The following is a description of a gene set: studied in species Mus musculus Any process that activates or increases the frequency, rate, or extent of antigen processing and presentation. Mouse Gene Set: GOBP_POSITIVE_REGULATION_OF_ANTIGEN_PROCESSING_AND_PRESENTATION, and this is the list of marker genes: Pycard, Trem2, Tap2, Clec4b2, Fam3d (NCBI Gene Id 218702), Cd74, Nod1, Ccr7, Nod2, Slc11a1, Ccl21a, Ccl19